The following is a description of a gene set: Genes containing one or more binding sites for (ZNF595) in their promoter regions (TSS -1000,+100 bp) as identified by GTRD version 20.06 ChIP-seq harmonization. Human Gene Set: ZNF595_TARGET_GENES species: Homo sapiens from publication Yevshin I, Sharipov R, Kolmykov S, Kondrakhin Y, Kolpakov F (PMID 30445619), and this is the list of marker genes: SMIM26, TEFM (transcription elongation factor, mitochondrial), SVOP, DAPL1, MTF2, TRIM41, ZNF233, PTPRG, OXCT1, LINC-PINT, JPX, GBA1, ENTPD8, MITD1, INTS12, VRK1, TCEA2, PSPH, IGFLR1, SMG7-AS1, COX6B1, BCAR3-AS1, EFNA3, RNU1-140P, PTP4A2, VPS51, GSTK1, DTD1, CCNL1, MRPL30, MAST2, CYP1A1, SLC39A11, CKB, SELENOH, HRCT1, TATDN3, KRTDAP, SMAD6, LRRC8A, ZNF689, SMG8, GLIPR1L1, CDH1, ZNF155, PEX3, SHMT2, MTND5P11, HACD3, GIN1, SF3A3, RCAN2, ZMPSTE24 (NCBI Gene Id 10269), RAB30, MIR4773-2, HEATR1, ADAP2, CPNE8 (copine 8), ZMPSTE24-DT, ZNF221, SF3B6, MIR4519, AURKAIP1, VPS25, C17orf75, KYAT1, SNHG10, DMAP1, RBBP5, DSTYK, GPSM3, DNAH14, CNTD1, MICB, DCP1A, GSTCD, NOLC1, ZNF540, CFAP20, STAT3, MAP2K5, MTCO3P12, GLUD1P3, RPL37, BMS1P4-AGAP5, GLRX5, ZFP69B, NCBP3, PPIP5K2, TARS2, CCNC, SSBP1, HROB, RPS15AP1, CTTNBP2, BMS1P4, SUPT5H, ZNF461, INTS14, LSM14A, SPEF2, SEC22B, CDK5RAP1, MRPL24, C11orf58, RAB30-DT, WEE2-AS1, SMG7, RPTOR, NSL1, METTL9, ADAT2 (NCBI Gene Id 134637), TVP23B, LINC00205, COA3, PLEKHG1, PAFAH2, SLC24A1 (solute carrier family 24 member 1), CD8A, REX1BD, FAM228B, MTMR9, PURPL, PDXK, ST3GAL6, ARMH3, EIF2B3, RNU5E-1, IQCH-AS1, SYNPO2, LINC01276, FRA10AC1